The following is a description of a gene set: Genes down-regulated in T98 cells (glioma) 48 h after treatment with interferon beta. Human Gene Set: NATSUME_RESPONSE_TO_INTERFERON_BETA_DN species: Homo sapiens from publication Natsume A, Ishii D, Wakabayashi T, Tsuno T, Hatano H, Mizuno M, Yoshida J (PMID 16140920) Alkylating agents, such as temozolomide, are among the most effective cytotoxic agents used for malignant gliomas, but responses remain very poor. The DNA repair protein O6-methylguanine-DNA methyltransferase (MGMT) plays an important role in cellular resistance to alkylating agents. IFN-beta can act as a drug sensitizer, enhancing toxicity against a variety of neoplasias, and is widely used in combination with other antitumor agents such as nitrosoureas. Here, we show that IFN-beta sensitizes glioma cells that harbor the unmethylated MGMT promoter and are resistant to temozolomide. By means of oligonucleotide microarray and RNA interference, we reveal that the sensitizing effect of IFN-beta was possibly due to attenuation of MGMT expression via induction of the protein p53. Our study suggests that clinical efficacy of temozolomide might be improved by combination with IFN-beta using appropriate doses and schedules of administration., and this is the list of marker genes: YWHAQ, RPLP1 (NCBI Gene Id 6176), SLIRP, TMSB10, GAS6, TNFRSF25, CD63, IGFBP6, MAPK6, ANXA2, GAPDH, PRDX6, XRCC5, COX6A1 (cytochrome c oxidase subunit 6A1), CAPN1, BAG1, HINT1 (histidine triad nucleotide binding protein 1), CD70, E2F1, PIN1, CDKN1C, SHC1, RPS2 (NCBI Gene Id 6187), TRAF3, MMP2, NR1H4, TPM2, PRDX1, NFKBIA, CD6, TXN, TP53I3, LGALS1, GSTO1, AGFG1, SEC61B, SOD1, NDUFB3, PPP2CA, TSHR, S100A2, COX4I1, COX6C, IL5RA, FTL, VDR, GSTP1 (NCBI Gene Id 2950), MNT, FTH1, CXCR1, SKP1